Given this list of marker genes DKC1, C1QTNF6, CDC6, SVIL, SDK2, SEH1L, SNX24, MMS22L, SYTL5, POLA2, PHLDA1, MCM5, SLC25A24, DTL, CD82 (CD82 molecule), ATP6V1C2, MAPT, UGCG, MCM4, CDCA7, MARS1, POLE2, FRK, MRPS23, NIP7, WDR46, FLNB, NMRK1, ECE2, COL12A1, PAX9, SCARB1, TMEM64 (transmembrane protein 64), SLC1A4, TMEM104, NAB2, CDC45, NT5DC3, PTGES, MYBL1, TIPARP, NXNL2, AREG, RARA, FEN1, MYC, SLC1A5, CCNE2, RAPGEFL1, PCNA (proliferating cell nuclear antigen), PGR, ARL3, ZNF185, IL17RB, PDCD11, ELOVL2, DEPTOR, MAMLD1, ZNF367, SEC14L2, CELSR2, MCM3, TPD52L1, BRCA1, CTPS1, SGK1, BLVRB, LYAR, IGFBP4, PXK, PLEKHH1, HELLS, BRIP1, ABCE1, NAV2, DDX21, B3GALNT1, RRP12, POLR1B, HR, RBL1, ISG20, PLAAT3, CD44 (NCBI Gene Id 960), AMD1, RERG, DNAJC12, MYOF, LRIG1, SYBU (syntabulin), TPBG, EMC3-AS1, BRI3BP, NOL6, LRP8, EXOSC5 (exosome component 5, NCBI Gene Id 56915), LRRFIP2, CNKSR3, ANXA9, PPAN, ELF1, DPM2, MYBBP1A, ISOC1, EXO1, KIF21A, OSTF1, OLFM1, PEX11A, JAK2 (NCBI Gene Id 3717), SFXN2, PRIM1, SGK3, TMEM120B, KCNK5, CHAF1A, SYTL4, ADCY9, NEMP1, UHRF1, MCM6, PLOD2, MICAL2, PRSS23, ABHD2, ALDH3A2, FKBP4, XRCC3, SLC27A2, SLC26A2, TMED8, AMZ1, ENDOD1, NOP2, TGM2, SEPTIN9, SLC22A5, EEIG1, USP31, SLC19A2, RAB31, CALCR, MCM8, GINS3 (GINS complex subunit 3), DDX10, FKBP5, H2AP, RUVBL1, UNG, MACF1, SLC7A1, WDHD1, TPM1, GAB2 (NCBI Gene Id 9846), NRIP1, SLC29A1, LONRF2, CA12, MYB, TICRR, CHEK1, FARP1, SEMA3B, SEPTIN5, NR2C2AP, MCM10, GINS2 (GINS complex subunit 2), PLAC1, WDR3, EGR3, MCM2, RPL32, RRS1, STC2, HSPB8, KCNK6, ANKH, DSCC1, SMOX, HIF1A, E2F1, OPN3, PKIB, MOCOS, XRCC2, RET, ATP11A, CXCL12, BCS1L, AKAP1, HEY2, SLC16A1, WDR76, CENPU, GREB1, MBOAT1, ASB13 (NCBI Gene Id 79754), NPY1R, TIAM1, SLC7A5, RFC3, AP1B1, RBBP8, HSPD1, TFAP4, PCP4, YARS1, LDLRAD3, SLC47A1, KRT13, TMA16, MCM7, GART, MTHFD1L, PPIF (peptidylprolyl isomerase F), CHRNA5, NHERF1 (NHERF family PDZ scaffold protein 1), NOLC1, BCL2, PIGW, PAICS, IFNAR2, WDR4, OLFML3, GLA, TMEM164, NOP56, NOS1AP, here is a description of the gene set: Alternative promoters (AP) occur in >30% protein-coding genes and contribute to proteome diversity. However, large-scale analyses of AP regulation are lacking, and little is known about their potential physiopathologic significance. To better understand the transcriptomic effect of estrogens, which play a major role in breast cancer, we analyzed gene and AP regulation by estradiol in MCF7 cells using pan-genomic exon arrays. We thereby identified novel estrogen-regulated genes (ERG) and determined the regulation of AP-encoded transcripts in 150 regulated genes. In <30% cases, APs were regulated in a similar manner by estradiol, whereas in >70% cases, they were regulated differentially. The patterns of AP regulation correlated with the patterns of estrogen receptor alpha (ERalpha) and CCCTC-binding factor (CTCF) binding sites at regulated gene loci. Interestingly, among genes with differentially regulated (DR) APs, we identified cases where estradiol regulated APs in an opposite manner, sometimes without affecting global gene expression levels. This promoter switch was mediated by the DDX5/DDX17 family of ERalpha coregulators. Finally, genes with DR promoters were preferentially involved in specific processes (e.g., cell structure and motility, and cell cycle). We show, in particular, that isoforms encoded by the NET1 gene APs, which are inversely regulated by estradiol, play distinct roles in cell adhesion and cell cycle regulation and that their expression is differentially associated with prognosis in ER(+) breast cancer. Altogether, this study identifies the patterns of AP regulation in ERGs and shows the contribution of AP-encoded isoforms to the estradiol-regulated transcriptome as well as their physiopathologic significance in breast cancer. Genes up-regulated in MCF7 cells (breast cancer) at 6 h of estradiol treatment. studied in species Homo sapiens from publication Dutertre M, Gratadou L, Dardenne E, Germann S, Samaan S, Lidereau R, Driouch K, de la Grange P, Auboeuf D (PMID 20406972) Human Gene Set: DUTERTRE_ESTRADIOL_RESPONSE_6HR_UP